The following is a description of a gene set: A cellular process that is involved in cytokinesis (the division of the cytoplasm of a cell and its separation into two daughter cells). species: Mus musculus Mouse Gene Set: GOBP_CYTOKINETIC_PROCESS, and this is the list of marker genes: Mtmr4, Anxa11, Spire2, Kif20b, Iqgap1, Mitd1, Chmp2a, Myh9, Plec, Rab11a, Vps4a, Snx18, Iqgap2, Racgap1, Chmp5, Ist1, Klhdc8b, Arf1, Rtkn, Snx33, Luzp1, Exoc7, Cep55, Aurkb, Vps4b, Kif20a, Chmp2b, Stx2, Spart (spartin), Zfyve19, Pdcd6ip, Chmp4c, Chmp7, Chmp1a, Cntrob, Nup62, Ect2, Chmp1b, Chmp4b, Rhoa, Chmp3, Alkbh4, Rab11fip3, Iqgap3, Arf6, Chmp6, Spire1, Snx9, Chmp1b2, Spast, Anln